Given this list of marker genes RFC4, PALB2, PCNA, RFC3, ATRIP, RPA1, MRE11, RBBP8, RAD51C, POLE, POLH, UBA52, EME1, BARD1, NBN, WRN, CHEK1, RAD51, RAD51B, GEN1, RAD51D, RHNO1, RPS27A, RFC5, SLX4, POLD4, RAD17, MUS81, POLE3, DNA2 (NCBI Gene Id 1763), RMI2, POLD1, RPA2, BLM, POLD3, POLK, UBB, RPA3, POLD2, POLE2, HUS1, TOP3A, SPIDR, RTEL1, RAD51AP1, RAD9A, RFC2, RMI1, RAD9B, RAD1, TOPBP1, BRIP1 (NCBI Gene Id 83991), XRCC3, BRCA2, KAT5, SEM1, RFC1, SLX1A, XRCC2, FIGNL1, EXO1, ATM, ATR, POLE4, BRCA1, FIRRM, UBC, RAD50, EME2, here is a description of the gene set: Reactome Pathway: HDR through Homologous Recombination (HRR) Homology directed repair (HDR) through homologous recombination is known as homologous recombination repair (HRR). HRR occurs after extensive resection of DNA double-strand break (DSB) ends, which creates long 3'-ssDNA overhangs. RAD51 coats 3'-ssDNA overhangs in a BRCA2-controlled fashion, creating invasive RAD51 nucleofilaments. The RAD51 nucleofilament invades a sister chromatid DNA duplex, leading to D-loop formation. After the D-loop is extended by DNA repair synthesis, the resulting recombination intermediates in the form of extended D-loops or double Holliday junctions can be resolved through crossover- or non-crossover-generating processes. part of: HDR through Homologous Recombination (HRR) or Single Strand Annealing (SSA) studied in species Homo sapiens